The following is a description of a gene set: species: Homo sapiens from publication Hollmann CA, Owens T, Nalbantoglu J, Hudson TJ, Sladek R (PMID 16585179) Genes down-regulated in DLBCL (diffuse large B-cell lymphoma) cell lines sensitive to stimulation of CD40 relative to the resistant ones. CD40 promotes survival, proliferation, and differentiation of normal B cells but can cause activation-induced cell death in malignant B lymphocytes. CD40 ligand and anti-CD40 antibodies have been used successfully to induce apoptosis in lymphoma lines both in vitro and in xenograft tumor models. Although this makes CD40 an attractive target for antitumor therapies, the response of malignant B cells to CD40 signaling is variable, and CD40 stimulation can enhance proliferation and can increase chemoresistance in some cell lines. It would therefore be useful to identify markers that predict whether a specific cell line or tumor will undergo apoptosis when stimulated with CD40 and to identify targets downstream of CD40 that affect only the apoptotic arm of CD40 signaling. We have analyzed gene expression patterns in CD40-sensitive and CD40-resistant diffuse large B-cell lymphoma (DLBCL) cell lines to identify signaling pathways that are involved in CD40-mediated apoptosis. CD40-resistant lines expressed pre-B-cell markers, including RAG and VPREB, whereas CD40-sensitive cells resembled mature B cells and expressed higher levels of transcripts encoding several members of the CD40 signaling pathway, including LCK and VAV. In addition, CD40-sensitive DLBCL cell lines also displayed constitutive activation of extracellular signal-regulated kinase (ERK) and failed to undergo apoptosis when ERK phosphorylation was inhibited. In contrast, CD40-resistant lines showed no constitutive activation of ERK and no increase in ERK activity in response to CD40 stimulation. Our results suggest that constitutive activation of ERK may be required for death signaling by CD40. Human Gene Set: HOLLMANN_APOPTOSIS_VIA_CD40_DN, and this is the list of marker genes: TRIM22, SYNGR3, SP140, PPP3CA, BRD3OS, PON2, ZNF544, HOMER1, SETMAR, SPTBN1, BZW2, ZNF302, STAMBP, SATB2, UTS2, E2F6, UBE2L6, FNDC3B, LY75, BTN3A3, ANXA5, RASGRP2, MTRF1, BCR, APBB2, ELOVL6, BAG3, GSE1, DPY19L1, RPL8, BACH2, SAV1, CASP1, VPS72, GOSR1, ZC3HAV1, SEC23IP, H2BC6, PKIG, FADS2, ZNF239, ANXA2P2, ZBTB18, GTF3C1, PPA2, NXN, TRAM1, CRYZL1, TSPO (translocator protein), RYK (NCBI Gene Id 6259, receptor like tyrosine kinase), RNF138, AEBP1 (AE binding protein 1), ZKSCAN4, GTF2H5, VIM, FOCAD, S100A11, NINJ1, NPC2, BRD3, CCNB1IP1, RHOA, PSMB9, GAB2, TCF4, TOR1AIP1, MGST2, ZNF22, OSR2, SATB1, IGHA1 (NCBI Gene Id 3493), CYB5R2, SUCLG2 (succinate-CoA ligase GDP-forming subunit beta), GATM, SLC16A3, HLA-E, HOXB6, MGAT2, GMFG, ELAPOR1, ABHD10, CD58, DECR1 (NCBI Gene Id 1666), ST3GAL5, GSTO1 (glutathione S-transferase omega 1), TRIM13, CRTC3, MSRB2, OXSR1, UROS, THUMPD2, RRBP1, NADK, TRIP6, IGLC2, AP3B1, PYCARD, MRPL57, HLA-F (NCBI Gene Id 3134), PPM1F, CPVL, KLHL21, QPRT, HSBP1, MSRB1, TIMM22, H1-2, HCP5, CTSC, SMARCE1, CASP4, TP53, RNASE6, FANCF, YBX3 (Y-box binding protein 3), USP7, SYNE3 (spectrin repeat containing nuclear envelope family member 3), RUBCNL, ATP6AP1, HDAC9, RPP25, AGPS, TAP2 (NCBI Gene Id 92048), PNMA1, BDH2, UGDH, ATP5MJ, MPZL1, EFR3A, CERS6, SIDT1, TFG, PSME1, CASP7, PDLIM1 (PDZ and LIM domain 1), TCL1A, LXN, PARP12, ARMCX6, PPP1CA, SEPTIN11, ACOT9, TMX1, EEF1D, CHMP2B, PCTP, GSDMD, MX2, ANXA2, ZAP70, TARS1, PSMB8, FAM174B, MBP, ANKRD10, IGLL1, DECR2, S1PR4, ABL1, PCBD1, CXCR4, SUB1, HLA-DRB4, PHYH, VPS16, PSPH, ZNF45, SERPINH1, RPH3AL (NCBI Gene Id 9501), NEK3, LDAH, CD9 (CD9 molecule), DNMT3A, TIMM9, CREG1, FADS1, SERPINB1 (NCBI Gene Id 1992), KLHL9, NLRP2, TES, H2AC6 (H2A clustered histone 6), ZNF274, SKAP1, GFUS, SERPINF1, NME4, ZSCAN9, PDE4B, TMEM131, TRIM44, LITAF, NUDT1, CRELD2, LRIF1, NOTCH2, BMP7, ZNF195, NOSIP, PGM1, LAMB4, XK, TLE1, ANKMY2, IGLL3P, MYD88, NUP42, RCN2, DENND5A, SMIM10L1, RTP4, RAG1, DENND2D, B3GALNT1, GTF3C3, IFT57, NAXD, STAT1, MT1X, AKIP1, CDH4, HOXB7, H2BC12L, ACOT13, IFITM3P7, CASP6 (NCBI Gene Id 839), HLA-G, GSTM1, NIT2, IFITM1, MSX1, HLA-J, VPREB1, LGALS3BP, IFIH1, RPN1, H2BC7, NDUFB8, LDB3, SLC39A4, CD79B, IFFO1, C8orf33, TDRD7, CDKN1B, PLXND1, MTMR2, DNPEP, KYAT3, HOXA10, RPL36AL, VWA8, SPINT2, THYN1, BABAM2, CTNNA1, CANX, MIPEP, GNPDA1, NAA35, HLA-B, F13A1, CPOX (coproporphyrinogen oxidase), COA3, ZNF124, RWDD2B, ACOT2